Given this list of marker genes KNCN, SNX25, BNIP3L, RSAD2, OASL, NLRP6, DTX3L, DNASE2B, ZSWIM5, DCDC2B, STAT1, IGLV1-44, RNF31, ZNF177, ZC3HAV1, IFNA8, PARP12, LINC01904, APOL6, CHSY3, SPATA45, TMEM258, GLRA3, OAS1, SLC22A24, OAS3, IFI27, GPM6A, PRKD2, ZNFX1, TRIM25, SPHK1, TEX44, EGR3, DDX60, SPACA1, HERC6, IQGAP2, IFIT2, THEMIS2, LPAR4, TRIM69, MIDEAS, ADAR, SAMD9, USP2, ANKLE1, ELF1, PRSS30P, VWA5B1, OLFM2, PLSCR1, NRIP2, SMIM5, BST2, CLVS2 (NCBI Gene Id 387358), TRIM21, RNF213, ISG15 (NCBI Gene Id 9636), TAP1, GLDC, LINC00158, GTPBP2 (GTP binding protein 2), HNMT, IFIT5, IFI44, C7orf33, SULT2A1, PHF11, GOT1L1, IL27, TNFAIP8L2, XIRP2, PAX9, TDRD7, C5AR1, CCDC13, AGTRAP, PRLHR, RTP4, HES5, DLGAP2, IRF9, CMTR1, SIDT1, OGFR, SP110, PEPD, MMP12, HLA-E, CX3CL1, PVRIG, DCDC2, H2AC18, LGALS3BP, LINC02609, NLRC5, DAZL (NCBI Gene Id 1618), NAPA, PLA2G4C, PARP14, USP42 (ubiquitin specific peptidase 42, NCBI Gene Id 84132), NTRK3-AS1, IFI44L, EIF2AK2, SNX29, IFI35, IFITM1, IRF1, CSF2RB, TRIM56, PNPT1, ERVFRD-1, RSPH1, NRG4, ODAD2, LINC00658, P2RX3, CLEC18A, MAGEC1, RAB34, MYD88, CARINH, STAT2, IFI16, NRG2, MMP7, TMC1, IFI6, RTN1, RBM43, CMPK2, ZNRD2-DT, PSME2 (proteasome activator subunit 2), FBF1, TTC36, AGTR2, FAM215A, LINC00525, HELZ2, SHFL, MYO3B, SFTA1P, IRF7, SAMHD1, DDX60L, AQP8, NEB, ANGPT1, H2AC15, BTN3A2, RIGI, FZD10-AS1, IFITM3, CATSPER2, NFE2, ABHD2, COL5A2, CHST7, VN1R2 (vomeronasal 1 receptor 2), RAB11FIP1, MAPT-AS1, PGBD4, KIF19, TEC (NCBI Gene Id 7006), H19, PML, ANKRD33B (ankyrin repeat domain 33B), CYTIP, IFIT1, DMRTC2, TMEM140, PAGE1, CFH, RGSL1, TREX1, SCAMP1-AS1, PARP9, CNTN5, CHRNE, XAF1, GBP5, USP18, CRYBA4, OAF, EID2B, SPATA1, CD300LB, IFIT3, NOD1, here is a description of the gene set: studied in species Homo sapiens Genes up-regulated in double positive thymocytes with ELK1 knockout: untreated versus stimulated by anti-CD3. Removal of the transcription factor SAP1a member of the Ternary Complex Factor (TCF) group of transcription factors which in conjunction with Serum Response Factor (SRF) has been shown to have a profound effect on positive selection in the thymus. When another TCF Elk1 is knocked out in mice there is no effect on positive selection unless it is on a Sap1a KO background where the phenotype is very severe. We have stimulated isolated double positive T cells (DPs) with anti-CD3 to mimic positive selection and compared basal and stimulated transcription across the four genotypes to discover the downstream targets of Sap1a involved in positive selection. from publication Costello P, Nicolas R, Willoughby J, Wasylyk B, Nordheim A, Treisman R (PMID 20554967) Human Gene Set: GSE21546_UNSTIM_VS_ANTI_CD3_STIM_ELK1_KO_DP_THYMOCYTES_UP